Given this list of marker genes TAB1, RPS27A, TAB2 (TGF-beta activated kinase 1 (MAP3K7) binding protein 2), MAP3K7, TRAF6, TICAM1, UBC, TAB3, UBA52, UBB, TLR3, here is a description of the gene set: TICAM1,TRAF6-dependent induction of TAK1 complex Human Gene Set: REACTOME_TICAM1_TRAF6_DEPENDENT_INDUCTION_OF_TAK1_COMPLEX studied in species Homo sapiens